Given this list of marker genes Micu2, Prkce, Letm1, Fate1, Slc25a27, Nol3, here is a description of the gene set: species: Mus musculus Any process that decreases the concentration of calcium ions in mitochondria. Mouse Gene Set: GOBP_NEGATIVE_REGULATION_OF_MITOCHONDRIAL_CALCIUM_ION_CONCENTRATION